Given this list of marker genes DUSP16, DUSP9, DUSP7, DUSP8, DUSP6, DUSP10, MAPK1 (mitogen-activated protein kinase 1), here is a description of the gene set: species: Homo sapiens part of: Oncogenic MAPK signaling Reactome Pathway: Signaling by MAPK mutants Mutations in ERK proteins (MAPK1 and MAPK2) are rare, with mutations reported in ~8% of cervical cancers and 1.5% of head and neck squamous cell carcinomas. MAPK proteins with activating mutations are often still dependent on upstream phosphorylation by MAP2K proteins, but support sustained downstream signaling by virtue of being resistant to inactivating dephosphorylations.